The following is a description of a gene set: Human Gene Set: GOBP_CELL_DIFFERENTIATION_INVOLVED_IN_METANEPHROS_DEVELOPMENT studied in species Homo sapiens The process in which relatively unspecialized cells acquire specialized structural and/or functional features that characterize the cells of the metanephros as it progresses from its formation to the mature state., and this is the list of marker genes: LAMB2, WWTR1, WNT9B, SALL1, STAT1, OSR1, CD34, YAP1, GREM1, PDGFB, LIF, TCF21, CTNNB1, NPHS2, SMO, SIX2, POU3F3, PAX2, PAX8, GDNF, ADIPOQ, WNT4